Given this list of marker genes GABBR1, SYT4, P2RX7, AVPR1A, STXBP1, DTNBP1, AVP, NTSR1, ADORA2A (adenosine A2a receptor), RAB3GAP1, KMO, here is a description of the gene set: Human Gene Set: GOBP_POSITIVE_REGULATION_OF_GLUTAMATE_SECRETION species: Homo sapiens Any process that activates or increases the frequency, rate or extent of the controlled release of glutamate.